The following is a description of a gene set: Mouse Gene Set: GOBP_POSITIVE_REGULATION_OF_MOLECULAR_FUNCTION Any process that activates or increases the rate or extent of a molecular function, an elemental biological activity occurring at the molecular level, such as catalysis or binding. species: Mus musculus, and this is the list of marker genes: Il6, Dnajc24, Zc4h2, Crtc2, Usp6nl, Mapk8, Mbp, Nrg1, Csf1, Adra2c, Atf2, Cflar, Btrc, Nkx3-1, Tgm2, Cd200, Acr, Kif14, Atp1b1, Grhl3 (grainyhead like transcription factor 3), Smarca4, Atp7a, Rgma, Ppp2r5b, Cxcl13, Sgsm3 (NCBI Gene Id 97997), Snx18, Gsk3a (glycogen synthase kinase 3 alpha), Fgf2, Ern2, Coa8, Vav1, Rgs14, Cib1, Wrn, Azin2, Nvl, Epo, Agrn, Abl2, Rapgef1, Sez6, Adam17, Ager, Adipoq, Rela, Aph1a, Lrp6, Sh3bp1, Cdc14b, Rab11fip2, Rad50, Epha1, Drd4, Tnnt3, Nod2, Snx13, Ufl1, Clu, Dusp19, Akap6 (A kinase anchor protein 6), Cdc20, Erp29, Slco3a1, Hip1r, Neurod1, Ptk2, Fgf10, Nlrp3, Tcim, Tenm1, Trim31, Arhgap6, Rps6ka5, Pik3r6, Igtp, Thap11, Avpr1b, Gpld1, Gsk3b, Edf1, Htt, Bcas3, Arhgap35, Actn2, Atp1b2, Cdh3, Bcar3, Ripor1, Fxn, Trim25, Strit1, Ccs, Adcy3, Mmp9, Pax6, Spatc1l, Fgf23, Chp1, Bdnf, F2r, Psmd10, Rhebl1, Rgs7, Plcl2, Plcg2, S100a1, Ikbke, Ntf3, Arhgef7, Il10, Txn1, Rfc4, Crebbp, Lhcgr, Dab2ip, Irf4, Ednra, Rtkn2, Spta1, Prkd2, Ppp2r3c, Stat3, Bmp2, Tpx2, Trim62, Zbtb7a, Rbck1, Trim12a, Wnt10b, Fzd1, Lims1, Casr, Mapk14, Ube2i, Zfp618, Pparg, Cab39, Ube2s, Ptprc, F2, Sesn2, Ephb6, Arhgap11a, Stub1, Syde1, Hdac6, Trim28, Ccnd2, Ect2, Ankrd42, Mmd2, Apoc2, Lars1, Atpsckmt, Arhgef5, Plaur, Xrcc4, Eif2ak2, Por, Hfe, Zc3h15, Reln, Hmgb1, Plin5, Crtc3, Lfng, Stx4a, Iqgap1 (NCBI Gene Id 52178), Park7 (NCBI Gene Id 57320), Ip6k2, Cdk5r2, Tlr3, Ltf, Syk, Eno1, Fzr1, Gclm, Gpihbp1, Add2, Chaer1, Arrdc3, Terf2ip, Als2, Ralgapb, Efna3, Adam9, Sirt2, Dstyk, Lrrfip1, Rnf220, Chrna7, Itgb1, Rab3gap1, Stil, Kitl, Dnajb2, Srcin1, Dhx9, Trim13, Wdr41, Terf2 (NCBI Gene Id 21750), Cracr2a, Adcy4, Arhgef16, Nme1, Kalrn, Mex3b, Tor1aip1, Sdhaf4, Zfp622, Mark3, Ftmt, Traf5, Gnb5, Zic2 (zinc finger protein of the cerebellum 2), Tlr2, Slc8a2, Cacnb3, Dlg1, Atp2a1, Rnf25, Vcp, Nek10, Map2k4, Usp17le, Myocd, Prkag2, Ptk2b, Ccdc125, Pih1d1, Pnlip, Hras, Rgcc (NCBI Gene Id 66214, regulator of cell cycle), Wnt2, Ccl19-ps4, Dtx3l, Fzd4, Bcr, Mapre3, Edn1, Apoh, Esr2, Eif4g1, Il4, Hnrnpk, Map3k13, Prkn, Cacna1d, Scarb1, Lpar5, Pfn2, Cav2 (caveolin 2), Fzd5, Crtc1, Cops8, H2bc1, Dnajb1, Pdcd10, Dab1, Nr4a2, Myc, Prss22, Mid1ip1, Grn, Epm2aip1, Plek, Plcl1, Drd1, Ccl24, Gpsm1, Rhoc, Rnf31, Mrnip, Rapgef6, Ptpn1, Cldn3, Tlr4, Ndufa4, Pcna, Ccl19-ps6, Kit, Slc27a4, Arhgef19, Tcl1, Brd4, Gch1, Aim2, Pdgfrb, F2rl1, Ccnd3, Ikbkg, Bcl10, Rfc3, Bmp4, Tsacc, Cldn5, Chtf8, Gsto1, Rapgef3, Cldn13, Camk2a, Pycard (NCBI Gene Id 66824), Prkcz, Gnal, Notch2, Lyn, Wnt3a, Ripk3, Igf1, Atp1b3, Rap1a (RAS-related protein 1a), Tescl (NCBI Gene Id 69301), Ran, Rgs6, Stradb, Irak1, Fgf1, Il18rap, Hdac1, Trib1, Rgs8, Tiam1, Wdr59 (NCBI Gene Id 319481), Gmnn, Krit1, Map4k4, Scrib, Ifng, Cd84, Apoe, Rgs1, Aktip, Evi5, Stim1, Lrrk2, Rapgef2, Dock9, Tsc1, Dynap, Nphp3, Btg1, Cytl1, Vdr, Cnksr3, Stac, Nppa, Traf2, Jtb, Lmo4, Clock, Myod1 (NCBI Gene Id 17927), Map4k2, Rtn4r, Ar (androgen receptor), Tbc1d7, Skp1 (S-phase kinase-associated protein 1), Pfn1, D1Pas1, Trim30c, Prlr, Tcf3, Cripto, Vtn, Prkci (protein kinase C, iota), Pxn (NCBI Gene Id 19303), Hipk3, Nedd9, Dazap2, Ddrgk1, Tbc1d30, Trim30b, Wnt4, Fzd8, Cemip, Ube2n, Cthrc1 (collagen triple helix repeat containing 1), Nr1h3, Map3k11, Mapk3, Fgfr3, Il24, Ern1, Anxa2 (NCBI Gene Id 12306), Rangap1, Net1, Tssk4, Sphk1, Ang, Angpt1, Map3k5, Wnt9b, Foxc1, Ddit3, Mapre1, Nlrc4, Abi2, Trim6, Fgfr4, Ahsa1, Ppp2ca, Gab1, Cass4, Psrc1, Ins2 (insulin II), Nrxn1, Aph1b, Ang5, Evi5l, Agap2, Parp9, Il1b, Prex1, Mmut, Ywhab, Ralgapa1, Add1, Mmd, Abcb1b, Erbb2, Dvl2, Rgp1, Eif2ak3, Pin1, Akt1, Map2k6, Ehd3, Iscu, Bmi1, Malt1, Trib3, Lamtor5, Slc11a1, Rwdd1, Trim27, Vmp1, Usp33, Ep300 (E1A binding protein p300), Rfng, Hipk1, Fgf14, Epb41, Itga6, Cox17, Nf1, Map3k7, Sp100, Asxl2, Pdgfc, Cacul1, Trim30d (NCBI Gene Id 209387), Trib2, Gstm7, S100a10, Ube2l3, Ccl19-ps3, Chi3l1, Nbn (NCBI Gene Id 27354), Nlgn3, Hdac4, Ric1 (NCBI Gene Id 77643), Tab2, Ripk2, Mtor, Cimap3 (ciliary microtubule associated protein 3), Trim26, Etaa1, Tead1, Nipsnap2, Cdt1 (NCBI Gene Id 97441), Hspa1b, Tigar, Hand2, Rassf2, Tpd52l1, Rgs10, Pak1 (p21 (RAC1) activated kinase 1), Cenpe, Nod1, Lrp8, Fgfr1, Rps2, Hmgb2, Sirt3, Rb1, Rcc2, Sez6l, Ndel1, Phb2, Ralb, Dnajc10, Nox4, Jak2, Mastl, Cd40lg, Fgfr2, Tfrc (transferrin receptor), Cnpy2, Tom1l1, Lrrc38, Prelid1, Il34, Rap1gap, Pim1, Map2k3, Rfc5, Sumo1, Kctd7, Adcy8, Stim2, Calm3, Ccn1, Apoa2, Chtf18, Snca, Fgf18, Ripk1, Ppp3ca, Sod1, Wnt11, Rara, Sirt1, Ank2, Ppia, Epha2, Fzd2, Isl1, Ceacam1, Esr1, Tunar, Insr, Myd88, Plk1, Plaa, Eif3e, Prkcq, Akt2, Rasgrp2 (NCBI Gene Id 386467), Stac2, Irak3, Agtr1b, Egf, Nmd3, Epha4, Pirt, Tab1, Map2k7, Cacnb2, Robo1, Abi3, Map3k4, Hdac2, Gpr65 (G-protein coupled receptor 65), Chp2, Tor1aip2, Capn3, Ctss, Il3, Crkl, B2m, Ncbp1, Srgap2, Tnnt2, Pinx1, Gpr39, Vegfc, Daxx, Hnrnpu, Ski, Antxr1, Pdgfb, Cd4, Hipk2, Cdk5r1, Cd24a, Ppargc1a (peroxisome proliferative activated receptor, gamma, coactivator 1 alpha), Odam, Tnfsf18, Psap, Adcy2, Cartpt, Plxnd1, Tlr6, Arhgap42, Ngf, Arap1, Tnf, Ccl5 (NCBI Gene Id 20304), Calm2, Niban2, Tnfsf11, Fcer2a, Emp2, Prkch, Smcr8, Mre11a, Pik3r5, Maged1, Map3k12, Lrrc55, Usp9x, Hdac5, Cln5, Lrrfip2, Hsf1, Fgd2, Psma6, Rpl11, Vldlr, Pik3cg, Fcgr2b, Dph3, Xrcc5, Mtmr9, Zeb2, Camk1d, Ttbk1, Agt, Jph2, Ang4, Il19, Gdnf, Ang2, C9orf72, Camk1, Topors, Adora2b, Gas6, Tmem106b, Tert, Sfrp2, Msh2, Lrrc52, Dscc1, Met, Htr2b, Asph, Trim21, Trappc9 (trafficking protein particle complex 9), Dnajc9, Trim5, Fcer1a, Pten, Creb3, Slc5a3, Pitx2, Ssbp1, Spdye4a, Abl1, Adcyap1, Mapre2, Pla2g5, Akap9, Egfr, Nr1h2, Slc37a4, Smarcb1, Adcy7, Cdk5 (NCBI Gene Id 12568, cyclin dependent kinase 5), Pot1a, Pygo2, Adra2b, Xrcc6, Tesc, Nts, Arhgap24, Zc3hav1, Akap7, Prox1, Eef1a2, Sash1, Cdc25b, Tns3, Ins1, Ror1, Stmn1, Spag8, Csf1r, Ccl19-ps1 (C-C motif chemokine ligand 19, pseudogene 1), Agtr1a, Mef2c, Ccl11, Trim38, Il20, Coro1c, Tlr1, Pou4f2, Syap1, Fam220a, Ppargc1b, Tbc1d2, Map2k1, Npnt, Stimate, Ripor2 (NCBI Gene Id 76622), C1galt1c1, Plxnb1, Cops5, Abr, Epha5, Msh6, Tm9sf5 (NCBI Gene Id 245423), Ajuba, Tank, Rhoa, Lrrc26, Rasgrp1, Dock8, Trim52, Vsir, Traf4 (NCBI Gene Id 320278), Edn3, Chtop, Prkd1, Fank1, Cacna1c, Efna1, Jup, Ripk4, Ikbkb (NCBI Gene Id 16150), Ctsh, Med25, Dock11, Ticam1, Slc1a1, Taok3, Ereg, Plpp3, Hes1, Edn2, Neurod2, Ddx3x, Dnajb11, Card10, Ctbp2, Itgb1bp1, Ppp1r3g, Psenen, Plcb1, Lep, Rfc2, Ralgapa2, Fer, Snx9, Trem2, Mid2, Casq1, Adrb2, Strada, Trim14 (NCBI Gene Id 74735), Ccl19, C1qtnf9, Prkcd, Crnn, Apoa1, Gal, Pik3ca, Bex2, Clspn, Flot1, Thbs1, Dhfr (NCBI Gene Id 71558), Hif1a, Thy1, Traf6, Setmar, Hmga2, Sipa1l1, Anxa3, Cd40, Cd74, Mst1r, Mapk8ip3, Mavs, Psen1, Foxj1, Trim32, Trpc6, Arrdc4, Hspa2, Neurog1, Phactr4, Unc119, Abi1, Ccl19-ps5, Il5, Ntrk3, P2rx7, Wnk2, Fnta, Bud31, Card14, Tcaf1, Wnk4, Map3k1, Tnfrsf11a, Gprc5b, Epb41l5, Carm1, Foxa1, Dock10, Rnf207, Nus1, Card11, Pabpn1, Orai1, Cldn4, Tirap, Itgb3, Apc2, Ralbp1 (ralA binding protein 1), Axin1, Dynapl1, Lilra5, Pkd2, Trim12c, Myo9b, Trim30a, Pip5k1a (NCBI Gene Id 18720), Arhgef2, Sgsm2, Wdr24, Pou4f1, Fbn1, Ide, Erc1, Ercc2, Rock1, Pdgfa, Gata3, Aph1c, Srf, Rgs16, Rps3, Ccnd1, Asap3, Arhgef10, Flt1, H1f0 (NCBI Gene Id 320750), Pibf1, Npm1, Bcl2, Chrna3, Hmgn1, Pot1b, Mfng (NCBI Gene Id 17305), Lmf1, Adgrf1, Rfk, Sez6l2, Rhog, Aldob, Rgn, Dock7, Lgals9, Dennd1a, Rcn3, Nedd4l, Fermt2, Trim37, Ntrk1, Ccny (cyclin Y), Apoa4, Stk11, Fgd4, Neurog2, Tmem132a, Cth, Polg2, Myl4, Map2k2, Prdx3, Crk, Ube2srt, Neurl1a, Nodal, Map3k10, Mtss2, Dmd, Abcb1a, Traf1, Rsu1, Magi3, Tbc1d20, Tcf7l2, Spdya, Hap1, Adra2a, Stox1, Irgm2, Wnt5a, Dact1, Dbi, Calm1, Csrp3, Grem1, Raf1, Ebf2, Irak2, Calcr, Il18, Blk, Mtdh, Sting1, Tgfbr3, Trim15, Ctnnb1, Cat, Ezh2, Plscr1, Ddx11, Dok7, Src, B3gat3, Higd1a, Scn1b, Tgfb2, Cav1, Rab7b, Tax1bp3, Ccl26, Twist1, Ank3, Nos3, Pkp4, Ncstn, Card9, Lrp1, Ccr7, Cdkn1a, Pde5a, Vangl2, Dhx33, Ddr2, Ifrd1, Adcy1, Irgm1 (NCBI Gene Id 15944, immunity-related GTPase family M member 1), Wnk3, Trim8, Stac3, Pin1rt1, Msh3, Rack1, Cftr, Syngr3, Il1rap, Fgf13, Mt3, Ang6, Mtpn, Apoa5, Galr2, Kdm4d, Il18r1, Fbxw7, Zfp91, Prtn3, Spon1, Apoc2l, Ccdc88a, Arid5b, Dennd1b, Calca, Hmgn3, Bambi, Cyp27b1 (NCBI Gene Id 216437), Sema4d, Eif3d, Rasgrf1, Dvl3, Slc9a1